Given this list of marker genes DCT, HGD, CTBP2, RORB, PCDHGA7, CARD16, PCDHGA5, ITGA1, PCDHGA10, PCDHGA3, ABCB7 (ATP binding cassette subfamily B member 7), PCDHGC3, PCDHGA9, TAOK1, ZMYM2, RTN3, HMGN3, ZNF470, NEUROD1, HNRNPH3, PCDHGB3, RCOR3, PSMA8, APPL1, TJAP1, PCDHGA11, SESTD1, PCDHGA12, EIF4G2, CRISPLD1, PRKD3, ACLY, RANBP1, PCDHGA2, EXPH5, PCDHGA1, USP53, BLTP3A, KIF20B, TNFAIP2, ANKIB1, WDR26, IKZF1, PREPL, SCN1A, MPZL3, PNISR, SLX4IP, PCMTD2, CTHRC1, SYPL2, DSG1, ANXA4, PCDHGB7 (NCBI Gene Id 56099), SEH1L, CFAP58, PCDHGA8, here is a description of the gene set: Human Gene Set: MIR10525_3P species: Homo sapiens from publication Chen Y, Wang X (PMID 31504780) Genes predicted to be targets of miRBase v22 microRNA hsa-miR-10525-3p in miRDB v6.0 with MirTarget v4 prediction scores > 80 (high confidence targets).